Given this list of marker genes PRKCE, FKBP1B, HES1, TCAF2, MRLN, MIR208B, CALM1, SEMG1, PPP3R1, PPP3CA, CAV3, NTSR1, CASQ2, PXK, KCNRG, HTR1B, STK39 (NCBI Gene Id 27347), MIR29B1, NHERF1, MIR200C, HTR2A, SUMO1, PTK2B, GOPC, NOS3, B2M (NCBI Gene Id 567), REM1, SLN, SLC30A1, CAMK2D, ADRA2A, OXSR1, KCNE2, MIR30D, WWP2, GABRE, CALCA, MIR1-1, CAV1, ATF4, VDAC1, CAB39, MIR212, PCSK9, ACTN2, EPO, TMBIM6, MIR24-1, HAMP, MCUB, SLC26A5, MIR34A, ATP1A2, AGT, GPR35, MMP9 (NCBI Gene Id 4318), CRBN, PACSIN3, PPIF, WNK1, GSTO1, SESTD1, BIN1, ISCU, CALM3, ANK3, TGFB1, STC1, PRKG2, NEDD4L, MIR103A1, LILRB1, GNB5, COMMD1 (NCBI Gene Id 150684), PPP3R2 (NCBI Gene Id 5535), INPP5K, CRHR1, UCP2, TRIM27, PLN, KCNH2, OSR1, LILRB2, KCNAB1, YWHAE, TLR9, KCNE5, UBQLN1, GRP, CBARP, EPPIN, BEST3, SERPINE2, CALM2, MIR208A, MIR424, MIR192, BCL2, PPP3CC, SPINK1, FMR1, MIR26A1, YWHAQ, MIR499A, UBR3, PPP3CB, RGS4, KCNQ1, MIR328, NEDD4, WNK4, CACNA1F, KCNE3, KEL, KCNE1, MIR448, NOS1, HCRT, here is a description of the gene set: Any process that stops, prevents, or reduces the frequency, rate or extent of the directed movement of charged atoms or small charged molecules into, out of or within a cell, or between cells, by means of some agent such as a transporter or pore. Human Gene Set: GOBP_NEGATIVE_REGULATION_OF_MONOATOMIC_ION_TRANSPORT studied in species Homo sapiens